The following is a description of a gene set: The process whose specific outcome is the progression of the secondary female sexual characteristics over time, from their formation to the mature structures. In female humans, these include growth of axillary and pubic hair, breast development and menstrual periods. Their development occurs in response to sex hormone secretion. studied in species Homo sapiens Human Gene Set: GOBP_DEVELOPMENT_OF_SECONDARY_FEMALE_SEXUAL_CHARACTERISTICS, and this is the list of marker genes: TGFB1, IRF2BPL, WNT5A, MED1, PHB2, STAT5B, AREG, STAT5A